The following is a description of a gene set: Phosphorylation of Shc at three tyrosine residues, 239, 240 and 317 involves unidentified tyrosine kinases presumed to be part of the activated receptor complex. These phosphorylated tyrosines subsequently bind SH2 signaling proteins such as Grb2, Gab2 and SHIP that are involved in the regulation of different signaling pathways. Grb2 can associate with the guanosine diphosphate-guanosine triphosphate exchange factor Sos1, leading to Ras activation and regulation of cell proliferation. Downstream signals are mediated via the Raf-MEK-Erk pathway.Grb2 can also associate through Gab2 with PI3K and with SHIP.<br><br>Figure reproduced from Gu, H. et al. 2000. Mol. Cell. Biol. 20(19):7109-7120<br>Copyright American Society for Microbiology. All Rights Reserved. Reactome Pathway: Interleukin receptor SHC signaling species: Homo sapiens part of: Interleukin-2 family signaling; Interleukin-3, Interleukin-5 and GM-CSF signaling, and this is the list of marker genes: IL3RA, PIK3R2, JAK3, CSF2RB, JAK2 (NCBI Gene Id 3717), SOS1, CSF2, IL3, INPPL1, GRB2, JAK1 (NCBI Gene Id 3716), SHC1, PIK3R1, GAB2, CSF2RA, IL2RG, IL2RB, IL2, PIK3R3, PTPN6, INPP5D, IL5, PIK3CB, IL2RA, PIK3CD, PIK3CA, IL5RA